Given this list of marker genes LMBRD1, ABCD4, here is a description of the gene set: part of: ABC transporter disorders; Defects in cobalamin (B12) metabolism studied in species Homo sapiens ATP-binding cassette sub-family D member 4 (ABCD4) is thought to mediate the lysosomal export of cobalamin (Cbl aka vitamin B12) into the cytosol, making it available for the production of Cbl cofactors. Cbl is an important cofactor for correct haematological and neurological functions. Defects in ABCD4 can cause methylmalonic aciduria and homocystinuria, cblJ type (MAHCJ; MIM:614857), a genetically heterogeneous metabolic disorder of Cbl metabolism characterised by decreased levels of the coenzymes adenosylcobalamin (AdoCbl) and methylcobalamin (MeCbl). Clinically, symptoms include feeding difficulties, poor growth, hypotonia, lethargy, anaemia and delayed development. Reactome Pathway: Defective ABCD4 causes MAHCJ